Given this list of marker genes PODXL, ZBTB20, TNFSF4, MFN2 (mitofusin 2), KDM5C, P2RY11, SYNJ1 (synaptojanin 1), LRRK2, FXN, CTSH, PINK1, HLA-DRB1, VPS13C, PARK7, NAXE, UCHL1, GPR101, BCKDK, PTPA, NEFL (neurofilament light chain), ZNF365, HLA-DQB1, CHCHD2, SPTAN1, HSD17B10, AIP, PRKN, UQCRQ, HMBS, CTNNB1, HTRA2, TSEN54, RNF13, DNAJC6, TMEM106B, DNM1L, SRCAP, VCP, MED13L, TREM2, PAK3, PI4K2A, SATB2, ALDH7A1, HCRT (hypocretin neuropeptide precursor), HPD, CLCN3, PRNP, NGLY1, ATXN7, PTS, CHMP2B, GLDC, FTL, SLC25A13, SNCA, PLPBP, CLN8, GRN, SQSTM1, GNS, MECP2, PTRHD1, MAPT, MOG, ALAD, PSEN1, CNBP, SLC19A3, here is a description of the gene set: Human Gene Set: HP_RESTLESSNESS studied in species Homo sapiens A state of unease is characterized by diffuse motor activity or motion, which is subject to limited control, nonproductive, or disorganized behavior. Restlessness